Given this list of marker genes STAT2, ARAP2, CCDC117, HERC6, FBXO34, ASAH2B, TMCC3, SEZ6, MISP, C21orf91, OSR2, IFNA2, DCP1A, STAT3, GDF2, ARMCX1, RNF213, CLDN5, CD80, GBP5, STK19, CSRNP1, NCOA7, TP53BP2, C1orf210, DDX60, TLK2, FAS, MKLN1, RARG, MAML2, C1GALT1, APOBEC3G, TAP1 (NCBI Gene Id 92050), SEMA6B, FEM1C, CFAP73, RIPOR2 (RHO family interacting cell polarization regulator 2), ZNF687, RPS6KA5, PRX, PAG1, IL1A, DMXL1 (Dmx like 1), OTUD1, PLSCR1, CCP110 (NCBI Gene Id 9738), UNC13A, SP140, TNFSF15, SECTM1, STOM, MAK, C3orf38, ISCA1, PDE4B, SHFL, NEMP1, PAX5, CARINH, TRIM26, ZBED1, MASTL (microtubule associated serine/threonine kinase like), HERC5, TRAF2, NMRAL2P, LYN, DNAJB4, SAMD9L, NKAPL, TCERG1L, DTX3L, CD274, ABTB2, CREM, ST7-AS1, NLRC5, ZNF267, IL6, C1QL1, IFNW1, CXCL9, ISG15, ZNRF2, LAD1, SLFN5, TNF, ANXA2R, NEXN, COL27A1 (collagen type XXVII alpha 1 chain), CCL20, CMPK2, SP140L, NAMPT, RTP4, TMEM268, BRIP1, CDRT15, GTPBP2, PHGR1, IFI44, DUSP16, DENND5A, APOL6, RNF144B, IDO1, PMAIP1, IFNA16, IFIT2 (interferon induced protein with tetratricopeptide repeats 2), PELI1, IRF7, PDZD7, LAMP3, ENSG00000254531, SLC9A3, WARS1, ZNFX1, MX2, MCUB, SAMD9, IL15, DUX4L8, DYRK3, GPBP1, DYNLT1 (NCBI Gene Id 6993), OAS3, CMTR1, SLC25A28, PNPT1, UBE2Z, GPR180, FUZ, DHX58, FAM43A, KCNJ2, STX17, SEMA6A, TPT1-AS1, HBP1, ATP2B3, CREB5, IRF1, PLEKHG5, HOMER1, MIR155HG, RTCB, ARL5B, GBP4, RIGI, ACTR10, ACOT9, SBK1 (SH3 domain binding kinase 1), TENT5A, ZBP1, EPSTI1, IFIT5, IFNL2, EVPLL, CSRP2, GAL3ST2 (galactose-3-O-sulfotransferase 2), MORN1, TRIM25, GALNT3, FAM135A, PARP14, ZC3H12C, PPP4R1L, FUT4, PRRG4, ZNF775, IFIT3, XAF1, IL18RAP, SQOR, AIM2, SLC31A2, H4C6, SIGLEC1, ETV7, DUSP5, IFIH1 (NCBI Gene Id 64135), TOR1B, CD38, NEDD9, CDC42EP3, TMEM140, CXCL1, GIMAP2, SELENOI, HELB, TMEM217, TRIM5, TENT4A, AMOTL2 (NCBI Gene Id 51421), EXT1, PCGF5, PI4K2B, MAP3K8, here is a description of the gene set: from publication Zaslavsky E, Hershberg U, Seto J, Pham AM, Marquez S, Duke JL, Wetmur JG, Tenoever BR, Sealfon SC, Kleinstein SH (PMID 20164420) species: Homo sapiens Genes down-regulated in comparison of control conventional dendritic cells (cDC) at 0 h versus cDCs infected with Newcastle disease virus (NDV) at 12 h. Human Gene Set: GSE18791_CTRL_VS_NEWCASTLE_VIRUS_DC_12H_DN The dendritic cell (DC) is a master regulator of immune responses. Pathogenic viruses subvert normal immune function in DCs through the expression of immune antagonists. Understanding how these antagonists interact with the host immune system requires knowledge of the underlying genetic regulatory network that operates during an uninhibited antiviral response. In order to isolate and identify this network, we studied DCs infected with Newcastle Disease Virus (NDV), which is able to stimulate innate immunity and DC maturation through activation of RIG-I signaling, but lacks the ability to evade the human interferon response. To analyze this experimental model, we developed a new approach integrating genome-wide expression kinetics and time-dependent promoter analysis. We found that the genetic program underlying the antiviral cell state transition during the first 18-hours post-infection could be explained by a single regulatory network. Gene expression changes were driven by a step-wise multi-factor cascading control mechanism, where the specific transcription factors controlling expression changed over time. Within this network, most individual genes are regulated by multiple factors, indicating robustness against virus-encoded immune evasion genes. In addition to effectively recapitulating current biological knowledge, we predicted, and validated experimentally, antiviral roles for several novel transcription factors. More generally, our results show how a genetic program can be temporally controlled through a single regulatory network to achieve the large-scale genetic reprogramming characteristic of cell state transitions.